Given this list of marker genes TMEM14A, GAS5, PTBP2, RAB29, EXOC7, H3C11, FGF7, KIFC1, CRYGC, RIC1, GNAZ, CRMP1, MYNN, SLC30A9, CDH2, PAX2, TMEM190 (NCBI Gene Id 147744), DDT, TAF4, APOH, TLR3, ITGA9, SLC36A1 (solute carrier family 36 member 1), MUC4, MAPK8IP2, SPEF1, F12, TTTY11, R3HDM4 (NCBI Gene Id 91300), PCDH17, NREP, FBN3, SPINK1 (serine peptidase inhibitor Kazal type 1), MAP6, CACNA2D1, COMP, XCL2, TTLL4, IL18BP, ESRP2, BACE2, THSD1, ABCC13, ACOX2, KLHL25, AURKC, GATA6, ZNF765, TMEM158, NUP160, ADRA2A, SLC22A2 (solute carrier family 22 member 2), ZFP28, TOR1B, KLHL28, RAD54B, PTGIS, BMERB1, COX4I1, CPN2, VPS13C, PRKD1, LGR4, CHEK1, AFP, BMAL1, PHF14, UMOD, PPP2R3A, LOXL1, TNFRSF11B, CFHR1, ZKSCAN3, BPI, SEMA3C, NUDT4, SIGLEC9, FMOD, PITPNB, MRTFB, EFNB3, GRB14, PDE1A, INA, DGKI, FGFBP2, IL1RAP, ARHGAP24, MAGOHB, here is a description of the gene set: Genes in the cancer module 481. Human Gene Set: MODULE_481 studied in species Homo sapiens